Given this list of marker genes Spred3, Spry1, Spry2, Spred1, Spred2 (sprouty-related EVH1 domain containing 2), Foxe3, here is a description of the gene set: Mouse Gene Set: GOBP_NEGATIVE_REGULATION_OF_LENS_FIBER_CELL_DIFFERENTIATION species: Mus musculus Any process that stops, prevents or reduces the frequency, rate or extent of lens fiber cell differentiation.